Given this list of marker genes PPARA, GATA6, MAPK14, GATA4, SPI1, FOXP3, here is a description of the gene set: Human Gene Set: GOMF_NFAT_PROTEIN_BINDING Binding to NFAT (nuclear factor of activated T cells) proteins, a family of transcription factors. NFAT proteins have crucial roles in the development and function of the immune system. species: Homo sapiens